Given this list of marker genes Ighv6-4, Ighv3-5, Ighv3-3, Pik3ca (phosphatidylinositol-4,5-bisphosphate 3-kinase catalytic subunit alpha), Pld3, Fcgr4, Ighg2c, Pld2, Pik3cb, Ighv7-4, Igkv1-133, Ighv8-9, Pla2g6 (phospholipase A2, group VI), Cd3g, Igkv11-125, Ighv13-2, Ighv6-5, Ighv5-12-4, Ighv5-17, Ighv5-4, Igkv1-117, Igkv8-21, Igkv1-99, Igkv1-132, Ighv8-4 (immunoglobulin heavy variable V8-4), Ighv5-15, Prkce, Ighv5-2, Ighv7-2, Igkv17-121, Plpp4, Igkv2-137, Pik3r2, Ighv6-7, Ighv8-8, Ighv8-6, Pik3r1, Igkv1-110, Iglc2, Ighv6-3, Igkv16-104, Ighv3-6, Plcg1, Plcg2, Ighv3-8 (NCBI Gene Id 780831), Igkv1-135, Cd247, Igkv20-101-2, Igkv1-88, Igkv2-109, Pld4 (phospholipase D family member 4), Ighv5-6, Syk, Ighv12-3, Plpp5, Ighv3-1, Igkv1-122, Igkv1-131, Ighv5-16, Ighv7-3, Ighv6-6, Ighv8-13, Ighv8-2, Ighv5-12, Ighv8-5, Ighv16-1, Ighg1, Prkcd, Fcgr2b, Iglc1, Igkv18-36, Ighv5-9, Ighv3-4, Igkv15-103, Ighv5-9-1, Igkv1-35, Igll1, Ighg3, Ighv8-11, Igkv2-112, Fcgr1, Ighv8-12, here is a description of the gene set: Role of phospholipids in phagocytosis Mouse Gene Set: REACTOME_ROLE_OF_PHOSPHOLIPIDS_IN_PHAGOCYTOSIS species: Mus musculus